The following is a description of a gene set: Mouse Gene Set: REACTOME_REGULATION_OF_EXPRESSION_OF_SLITS_AND_ROBOS Regulation of expression of SLITs and ROBOs studied in species Mus musculus, and this is the list of marker genes: Dag1, Slit2, Usp33, Ubb, Ubc, Uba52, Rps27a, Uba52rt